The following is a description of a gene set: Any process that modulates the frequency, rate or extent of tRNA metabolic process. Mouse Gene Set: GOBP_REGULATION_OF_TRNA_METABOLIC_PROCESS studied in species Mus musculus, and this is the list of marker genes: Akt1, Nsun2, Ang, Slfn2, Mettl1 (methyltransferase 1, tRNA methylguanosine), Trdmt1